The following is a description of a gene set: from publication Cui A, Huang T, Li S, Ma A, Pérez JL, Sander C, Keskin DB, Wu CJ, Fraenkel E, Hacohen N (PMID 38057668) Cytokines mediate cell-cell communication in the immune system and represent important therapeutic targets. A myriad of studies have highlighted their central role in immune function, yet we lack a global view of the cellular responses of each immune cell type to each cytokine. To address this gap, the authors created the Immune Dictionary, a compendium of single-cell transcriptomic profiles of more than 17 immune cell types in response to each of 86 cytokines (>1,400 cytokine-cell type combinations) in mouse lymph nodes in vivo. A cytokine-centric view of the dictionary revealed that most cytokines induce highly cell-type-specific responses. For example, the inflammatory cytokine interleukin-1β induces distinct gene programmes in almost every cell type. A cell-type-centric view of the dictionary identified more than 66 cytokine-driven cellular polarization states across immune cell types, including previously uncharacterized states such as an interleukin-18-induced polyfunctional natural killer cell state. Mouse Gene Set: CUI_CDC2_IL23_RESPONSE_UP Genes positively differentially expressed in cell type: cDC2 (conventional dendritic cell type 2) upon treatment with cytokine: IL-23 in mouse lymph nodes in vivo. species: Mus musculus, and this is the list of marker genes: Naa20, Pdia3, Srsf9, Slfn2, Stard3, Pfn1, Lilrb4a